Given this list of marker genes IL1A, LPL, RGCC, EPAS1, MARCKS, NT5E, TPBG, IL18R1, UGCG, NRCAM, PLA2G4A, MMP1, HSPA1B, MEST, ID3, IGFBP7, CADM1 (NCBI Gene Id 337934), IGFBP3, STC2, CRLF1, PLAUR, IL6, SDC4, TFPI2, DMD, COL3A1, ALDH3A1, COL15A1, ANP32A, NMU (neuromedin U), IER3, TPM1, CD55, SLC16A3, SOD2, VEGFC, NNMT, KCNK1, here is a description of the gene set: Tumor hypoxia is an adverse prognostic factor. In a recent study, we could demonstrate that cyclic hypoxia selects for hypoxia-tolerant tumor cells, which are cross-resistant to other stimuli of mitochondrial death pathways. In contrast, sensitivity of the cells to death-receptor ligands was mainly not affected. The aim of the present study was to further elucidate cellular changes induced by cyclic hypoxia and to identify alterations in gene expression pattern upon hypoxic selection by means of DNA-microarray analysis. Our data reveal that cyclic hypoxia resulted in the selection of cells with resistance to doxorubicine and radiation. Furthermore, hypoxic selection was accompanied by constitutive changes of the gene expression pattern with downregulation of 156 and upregulation of genes. Most of the differentially regulated genes were involved in cellular responses to hypoxia and reoxygenation. While many of the genes that were downregulated upon hypoxic selection represent genes that are usually upregulated by acute hypoxia, the genes that were upregulated represent genes that are involved in stress resistance and anti-apoptotic signalling. Most importantly, hypoxic selection was not associated with changes of single apoptosis relevant genes, but with alterations in gene expression levels of a wide variety of genes indicating a more complex adaptation process. studied in species Homo sapiens Genes most down-regulated in hypoxia tolerant NCI H460 cells (lung cancer). Human Gene Set: WEINMANN_ADAPTATION_TO_HYPOXIA_DN from publication Weinmann M, Belka C, Güner D, Goecke B, Müller I, Bamberg M, Jendrossek V (PMID 15897868)